The following is a description of a gene set: species: Mus musculus The cleavage and rejoining of intermediates, such as Holliday junctions, formed during DNA recombination to produce two intact molecules in which genetic material has been exchanged. Mouse Gene Set: GOBP_RESOLUTION_OF_DNA_RECOMBINATION_INTERMEDIATES, and this is the list of marker genes: Rmi2, Rmi1, Xrcc3, Blm, Gen1, Top3a